The following is a description of a gene set: An abnormality of refraction characterized by the ability to see objects nearby clearly, while objects in the distance appear blurry. Human Gene Set: HP_MYOPIA Myopia studied in species Homo sapiens, and this is the list of marker genes: SDHD, GTPBP2, ADAMTS2, FLII, COL1A2, ATRX, NALCN, SON, TDO2, GJA1, RAB28, EMC1, CHM, SMARCC2, ASPH, DNAJC21, ANTXR1 (ANTXR cell adhesion molecule 1), PLOD3 (procollagen-lysine,2-oxoglutarate 5-dioxygenase 3), DNAJC30, VPS13B, CRYAB, RPE65, CRIPT, P4HTM (prolyl 4-hydroxylase, transmembrane), CANT1, SMARCA4, CACNA1F, USP7, PLOD1, ADAMTSL4, RAD21, TSPAN7, KCNE5, SLC2A10, ARL6, LRP5, ALDH18A1, TARS1, CRYGC, PACS2, BUD23, EXOSC2 (NCBI Gene Id 23404), FN1, UCHL1, WDR26, TUB, COL9A2, TEAD1, FZD5, GJC2, TAF1, RPGR, ELOVL4, CTNNB1, SDHB, POMT1, HERC2, COL4A3, GTF2I, SCO2, FLNA, TNPO2, RFC2, EFL1, FKTN, TTC8, BICRA, TRPM1, NYX, AP1B1, LRAT (NCBI Gene Id 9227), NEDD4L, GTF2H5, BAZ1B, XYLT1, COL11A1 (collagen type XI alpha 1 chain), PWAR1, DOHH, CAMTA1, ATP6V0A2, AEBP1, ARID1A, ADAMTS18, NONO, NCF1, CHD6, GPR143, ERBB3, DPH5, SMS, CRELD1, COX7B, BRD4, CLDN16, PAX2, KCNV2, CRYBA2, EIF4H (eukaryotic translation initiation factor 4H), PNPLA6, PDE6B, TRNT1, MED12L, TTLL5, WAC, KIF11, ARCN1, MED13L, RERE, NIPBL, HADHA, BBS2 (Bardet-Biedl syndrome 2), NR2F1, COL11A2 (collagen type XI alpha 2 chain), SOX11, LIMK1, COL5A1, CLDN19, ASXL1, ELP1, CRYGD, LCA5, TRAPPC11, KDM5C, LIG4, SLITRK6, PCYT1A, PAK2, ARR3 (NCBI Gene Id 407), COL4A1, SOX10, ADAMTS17, PDZD7, FKBP14, BLOC1S3, PUF60, PMM2, TFAP2A, SLC39A5, XYLT2, UBAP2L, NMNAT1, THOC6, MKRN3, RP1, FBN2, IFT52, ATAD3A, SRCAP, TCF20, PEX11B, BPTF, TFAP2B, CCNQ (cyclin Q), OPN1LW, SOX4, SETD5, VARS1, POGZ, DPF2, ATP6V1A (NCBI Gene Id 523), POLR3B, COL2A1, CAMK2G, VCAN, IRX5, ALDH3A2, POLR1C, SOX9, CNGB3, AGBL5, PIK3R1, HUWE1, TMEM63A, MFSD8, TULP1, NPAP1, RAI1, EPHA2, CPSF1, GNB3, MAGEL2, HDAC8, LOX, RP2, ANKRD11, MADD, ACOX1, USF3, BAP1, FKBP6, PPP1R21, IFT27, NDRG1, COL9A3, RPL10, GLRB, GNAT1, CBS, EXOSC5, VPS37D, CSPP1, PRR12, HSPG2, DEAF1, GPR179, INTS11, ZNF408, CHST14, YME1L1, PTPN11, AFF4, LTBP2, ACSL4, WHRN, SPTSSA, CAPRIN1 (cell cycle associated protein 1), CREBBP, ATP6V1B2, FANCI, DYRK1A, IFIH1 (interferon induced with helicase C domain 1), B3GLCT, PTEN, FBN1, ERCC2, PRDM5, GNAT2, POC1B, PPOX, MAN2B1, ZNF644, COL4A5, MBTPS2, USP9X, RIN2, CFAP418, SMARCD1, LRPAP1, NSUN2, TBC1D24, LAMA1, CLIP2, KDM5B, POLR3A, PURA, POMGNT1, FZD4, SMARCAL1, NFIX, CARS1, KCNH1, AGK, CRYBA4, PRPS1, RHO, TFE3, DPYD, SMC1A, EIF2S3, OFD1 (OFD1 centriole and centriolar satellite protein), TMEM94, SMARCB1, SLC25A4, ADGRV1, HACE1, ZEB2, GRK1, PDZD8, TAF6, TMEM270, GTF2IRD2, ZSWIM6, TWIST2, KAT6A, LRRC32, CRYBB2, BCL11B, COL12A1, SOX5, H4C5, THG1L, SEC23B, ELN, ABCC6, H4C3, BBS1, ZMYM3, NOTCH2, FGFR3, CCDC28B, HNRNPK, COL9A1, SNORD116-1, CHMP1A, WDR35, PDE6C, NPR3, AMMECR1, CDC45, CRYBB1, B3GALNT2, IPO8, EED, KAT5, B3GALT6, RHOA, COL4A4, ACBD6, TIMM8A, PPP2R5D, GTF2E2, SDHC, MAF, AHDC1, GMPPB, CACNA2D4, GLE1, GLRA2, OPN1MW, RMRP, FGFR2, GTF2IRD1, ASCC3, IGF1, LAMB2, MC1R, MYOC, AP3D1, IQSEC2, USH2A, COL18A1, NRAS, POMK, AARS1 (NCBI Gene Id 16), CYP4V2, SPATA7, APC2, CDK8, OPTN, ATF6, RECQL4, TGFBI, TBL2, GPAA1, ZFX, P4HA2, FBXW11, LOXL3 (lysyl oxidase like 3), TEK, EBF3, PRIMPOL, CRPPA, P3H2, CRYAA, PIGA, SAG, MYO1H, KLLN, TTR, SLC24A1, MYT1L, FBXO11 (F-box protein 11), B4GALT1, ZNF469, TBC1D7, LARGE1, COL4A6, GNPTG, SKI (NCBI Gene Id 6497), DAG1, NSD1, BFSP2, CASK, SMC3, PIGT, POMT2, ARID1B, FKRP, GRM6, HERC1, PWRN1, CYP1B1, NT5C2, CNGA3, ERCC3, DSE, AIFM1, ADAMTSL1, MSX2, TCF4, RNU4-2, LRP2, SETBP1, HS6ST2, ERI1, SNRPN, NDP, TLK2, VPS50, GPR156, BRAF, HCCS, ARID2, MANF, IFT43 (NCBI Gene Id 112752), TRIT1, MPLKIP (M-phase specific PLK1 interacting protein), HTT, C12orf57, WDR19, ADAMTS10, KIAA0586, MAP2K2, UBE3A, RNF113A, MYO5A, SNORD115-1, ATP6V1E1, CABP4, NBAS (NCBI Gene Id 51594), PDE6H, MAP2K1, EFEMP1, AKT1, PACS1, NDUFB11, LRIT3, PSMD12, KRAS, UNC119, SHOC2, GJA8, TYR, JAG1, MBD5, MYO7A, METTL27, SLC12A6, IFT122, SMARCE1, PIK3CA, RBM10, RPGRIP1, STX1A, OCA2, UBE3B, TKFC, GZF1, OAT, BMP4